Given this list of marker genes MMGT1, NIPAL2, NIPAL4, NIPA2, NIPAL1, CNNM4, ZDHHC13, CNNM2, NIPAL3, SLC41A1, TRPM7 (transient receptor potential cation channel subfamily M member 7), TMEM94, TUSC3, SLC41A3, CLDN16, TRPM6, SLC41A2, MRS2, MAGT1, NIPA1, here is a description of the gene set: Human Gene Set: GOMF_MAGNESIUM_ION_TRANSMEMBRANE_TRANSPORTER_ACTIVITY species: Homo sapiens Enables the transfer of magnesium (Mg) ions from one side of a membrane to the other.